Given this list of marker genes Trank1, Mybl1, Arfgap2, Traf3, Abtb2, Tcaim, Xpo7, Plxna2, Smim13, Reck, Cc2d1b, Cbfa2t3, Cpsf7, Lrp6, Cdc37l1, Slc13a3, Nudt7, Pex13, Unc80, Tuba4a, Kcnj2, Ccdc6, Islr, Zfp367, Ippk, Dync1li2, Slc25a22, Htr4, Slc25a37, Ubr3, Mgat4a, Rfc1, Zcchc3, Mex3c, Rnf144b, Usp25, Tab3 (TGF-beta activated kinase 1/MAP3K7 binding protein 3), Il7r, Clock, Bace1, Slc4a8, Rab10, Capns1 (calpain, small subunit 1), Pik3r1, Nynrin (NCBI Gene Id 97925), Mob3b, Smad7, Prrc2c, Nav1, Gcc2, Pip4p2, Son, Akap11, Btrc, Sall1, Ago4, Acvr2a, Atxn2, Kcnk10 (NCBI Gene Id 77454), Zyx, Cdca4, Mob4, Myt1l, Aar2, Rab11fip1, Clspn, Dennd10, Phf19, Satb2, Tmem74b, Armcx6, Man2a2, Myb, Nudt4 (NCBI Gene Id 71207), 6430571L13Rik, Cyp26b1, Fermt2, Peli3, Akt3 (thymoma viral proto-oncogene 3), Dcp1a (NCBI Gene Id 75901), Tenm2, Plxnc1, Ubfd1, Erlin2, Rubcn, Nrbp1, Sesn1, Zfp300, Gm12886, Tll1 (NCBI Gene Id 21892), Pskh1, Prmt6, Med1, Gpatch8, Ano3, Rere, Znrf2, Atxn7l3, Scoc, Ezh1 (NCBI Gene Id 14055), Rreb1, Usp15, Fbxw7, Vegfa, Dsel, Sema3a, Pappa, Ankrd13b, Rasgef1b, Plagl1, Sptbn2, Colq, Onecut2, Ccnd2, Hapstr1, Wwp1, Grm7, Slc20a2, Ash1l, Septin2, Amotl1, Ahcyl2, Actr2, Atp2b2, Il10ra, Zfhx4, Pth, Abl2, Wnt7a, Lrrc32 (leucine rich repeat containing 32), Tgfbr3, Ncapg2, Raf1, Sema6d, Stradb, Ptpn4, Adrb2, Cobll1, Aff4, Rab9b, Btbd8, Adissp, Chd2, Adgrl1, Cmpk1, Kif23, Rubcnl, Mfn2, Ptpn3, Nol4l, Ppp1r11, Zfhx3, Rnf10, Ythdc1, Omg, Socs6 (suppressor of cytokine signaling 6), Klc4, Ist1 (NCBI Gene Id 71955), Trabd2b, Btg2, Cert1, Pafah1b1, Tacc1, Avl9, Acvr2b, Ccnt2, Adamts3, Ptprr, Nrn1, Polr3f, Arhgap12, Phf20, Cd2ap, Atf6, Pou2f1, Usp31, Nup210, Ankrd46, Capn6, Hus1, Cdk17 (cyclin dependent kinase 17), Kbtbd2, Pacsin2, Epha7, Lats1, Fbxo21, Kif1b, Slc4a4, Crebrf, Rgp1, Rad9a, Ywhah, Luzp1, Ccdc85b (coiled-coil domain containing 85B), Eda, Wipi2, Srpra, Seh1l, Cntnap1 (NCBI Gene Id 53321), Pnpla6, Lurap1l, Slc4a7, Dll1 (NCBI Gene Id 13388), Helz, Zbtb34, Tfap2a, Kpna1, Sec14l1, Arl2, Nufip2, Dixdc1, Axin2 (axin 2), Spred1, Cldn12, 1700025G04Rik, Gm5460, Rnf217, Idh3a, Iars1, Akap7, Anks1, Sec24a, Cpeb3, Sez6l, B3gnt6, Zmym2, B4galt1, Nectin1, Qki, Rasef, Plxna4, Reln, Ago1, Kif21a, Rfx3, Csrnp1, Itpr1, Ddx3x, Kif1c, Zbtb44, Caprin1, Lhx3, Cnot6l (NCBI Gene Id 338514), Slc7a2, Ncs1, Tmem178b, Lrig1, Casr, Higd1a, Ppm1d, Ppm1e (NCBI Gene Id 327991), Suco, Krtap26-1, Dclk1, Kif5b, Adgrl2, Fbln5, Chac1, Smurf1, Tmem135, Dll4, Cdk5r1, Sec61a1, Kif5c, Fam135a, Slitrk6, N4bp1, Wee1 (NCBI Gene Id 22390), Bicd1, Atp1b4, Apln, Chek1, Tmcc1, Cops7b, Atp7a, Wnk3, Rspo3, Phc3, Pwwp2b, Nuak2, Igf2r, Entpd7, Cbx4, Prdm4, Med26, Pam, Rarb (retinoic acid receptor, beta), Hoxa10 (NCBI Gene Id 15395), Bcl2l2, Plcxd2, Mapkap1, Pnp2, Tnrc6b, Cdc25a (cell division cycle 25A), Hectd1, Zfp622, Wnt3a, Dcaf7, Cpd, Tbpl1, 2810459M11Rik, E2f7, Ccnjl, Ski, Ttll6, Kmt2a, Trp53inp2, Desi1, Zfp449, Chpt1, E2f3, Gpr63, Rbm6, Zfp809, Cpeb2, Drd1, Ghr, Spsb4, Eif3a, Fmn2, Abhd13, Bmpr1a, Fgf9, Insyn2a, Ube2q1, Nfe2l1, Prkar2a, Mmd, Pdxk, Usp12, Cacna2d1, Crebl2, Dnajc16, Spryd3, Bcl2, Slc39a10, Ube4b, Wbp11, Sall4, Sel1l3, Cfap45, Tmem87b, Tbp, Hmga1, Slc6a11, Arhgdia, Map2k1, Pnoc, Garem1, Kcnn4, Armh4, Zfp275, Zswim3, Ell, Nfatc3, Rad23b, Atg14, Stxbp3, Kdsr, Ret, Setd3, Gbp2b, Shoc2, Acsl4, Slit2, Tlk1, Usp42, Kctd8, Phip, Ccr2, Phactr2, Penk, Sgk1, Nlrx1, Klc1, Nos1 (NCBI Gene Id 76730), Jarid2, Hectd4, Etnk1, Plekhh1, Fgf7, Zbtb39, Klhl2, Kl, Col12a1, Ppp6c, Usp14, Ubn2, Sik1, Pla2g15 (NCBI Gene Id 97483), Tbl1xr1, Cdk12, Pip4p1, Ppp2r1b, Usp9x, Erc2, Sox6, Kcnq5, Fam151b, Plekhm3, Ccne1, Pappa2, G0s2, Nup50, Angel1, Hephl1, Selenoi, Lrig2, Atxn1l, Rictor, Cacul1, Eya1, Syde2, Fasn, Cbx6, Arih1, Spag7, Ints6l, Krtap11-1, Plpp1, here is a description of the gene set: from publication Chen Y, Wang X (PMID 31504780) Genes predicted to be targets of miRBase v22 microRNA mmu_miR_15a_5p in miRDB v6.0 with MirTarget v4 prediction scores > 80 (high confidence targets). Mouse Gene Set: MIR_15A_5P studied in species Mus musculus